Given this list of marker genes KRAS, NTRK2 (NCBI Gene Id 4915), SHC1, SOS1, BDNF, GRB2, HRAS, NRAS, NTF4, here is a description of the gene set: Activation of the neurotrophin receptor NTRK2 (TRKB) by BDNF or NTF4 triggers downstream RAS signaling. The best studied mechanism for activation of RAS signaling downstream of NTRK2 is through SHC1-mediated recruitment of the GRB2:SOS1 complex, triggering SOS1-mediated guanine nucleotide exchange on RAS and formation of active RAS:GTP complexes. part of: Signaling by NTRK2 (TRKB) Reactome Pathway: Activated NTRK2 signals through RAS studied in species Homo sapiens